The following is a description of a gene set: studied in species Homo sapiens Human Gene Set: REACTOME_METABOLISM_OF_NITRIC_OXIDE_NOS3_ACTIVATION_AND_REGULATION Metabolism of nitric oxide: NOS3 activation and regulation, and this is the list of marker genes: LYPLA1, DNM2, ZDHHC21, DDAH1, AKT1, NOS3, CAV1, CYB5B, NOSTRIN, NMT1, CALM1, SPR, CYGB, NOSIP, HSP90AA1, WASL, NMT2